The following is a description of a gene set: from publication Busconi L, Bauer JW, Tumang JR, Laws A, Perkins-Mesires K, Tabor AS, Lau C, Corley RB, Rothstein TL, Lund FE, Behrens TW, Marshak-Rothstein A (PMID 18025183) We have previously shown that rheumatoid factors (RF) produced by Fas-deficient autoimmune-prone mice typically bind autologous IgG2a with remarkably low affinity. Nevertheless, B cells representative of this RF population proliferate vigorously in response IgG2a/chromatin immune complexes through a mechanism dependent on the sequential engagement of the BCR and Toll-like receptor 9 (TLR9). To more precisely address the role of both receptors in this response, we analyzed the signaling pathways activated in AM14 B cells stimulated with these complexes. We found that the BCR not only serves to direct the chromatin complex to an internal compartment where it can engage TLR9 but also transmits a suboptimal signal that in combination with the signals emanating from TLR9 leads to NF-kappa-B activation and proliferation. Importantly, engagement of both receptors leads to the upregulation of a group of gene products, not induced by the BCR or TLR9 alone, that include IL-2. These data indicate that autoreactive B cells, stimulated by a combination of BCR and TLR9 ligands, acquire functional properties that may contribute to the activation of additional cells involved in the autoimmune disease process. Human Gene Set: GSE6674_ANTI_IGM_VS_ANTI_IGM_AND_CPG_STIM_BCELL_DN studied in species Homo sapiens Genes down-regulated in B lymphocytes: anti IgM versus anti IgM and CpG oligodeoxynucleotide 1826., and this is the list of marker genes: NDFIP2, EIF3B, KIAA1191, ERGIC1, GOLGA7, HSPA4, CNDP2, DCTD, MRPS10, NOL9, SPRED1, SLC52A2, AFG2B, ASNS, NOL10, MFSD2A, RCN1, EXOSC7, ZNF608, UBQLN1, HEMK1 (NCBI Gene Id 51409), CISH (cytokine inducible SH2 containing protein), SESN2, AEN, MTHFD1 (NCBI Gene Id 4522), PPAN (peter pan homolog), LTA (NCBI Gene Id 4049), FBXO30, TMCO3, PPHLN1 (NCBI Gene Id 51535), ATAD3A (NCBI Gene Id 55210), NOC2L, SLC7A5, PRMT1, PIM1, SEPTIN9, KCNK5, ZCRB1, SND1, CCT3, C7orf50, TGIF2, REXO2, PUM3, NDUFAB1, ELP1, ACLY, NOC4L, SLC4A7, KANSL2, ADSL, EBNA1BP2 (EBNA1 binding protein 2), LRP8, AQP9, PANK3, TIMM8A, HSPA9, TAFA3, SLC2A1, CHCHD4, UTP15, TGFB1, BCL2L1, G3BP1, HOMER1 (homer scaffold protein 1), UCK2, DIS3, MAT2A, LARP4, DDX54, PGLYRP2, KAT2A, SOCS1, SMYD5, PRNP, NAP1L4, YAF2 (NCBI Gene Id 10138), BTG3, TBRG4, C1QBP, GNL2, ARID5A, ATIC, PPP1R3B, CHAC1, CCDC86, HOOK1, SHMT1, PC, BDH1, SNRPA, MARS1, TNFRSF9, HBEGF, ELAVL1, FBL, NOLC1, PIM3, MYC, IFRD2, FAM118B, PHB1, NHP2, SMYD2 (SET and MYND domain containing 2), EIF2B3 (NCBI Gene Id 8891), ZMYND19, CYB5A (NCBI Gene Id 1528), XPOT, IFNG, USP27X, CLPTM1L, IDH3A, RRP1B, GPD2, NSUN5, RRAGD (Ras related GTP binding D), MAK16, SYPL1 (NCBI Gene Id 6856), BMS1, EIF2S1, TRIB3, GEMIN4, TEX2, CTPS1 (NCBI Gene Id 1503), NOP2, POLD2, NOL11, GARS1, FKBP1A, HCCS, WDR74, TMEM158, NLE1, WDR36, CCND3, ZNF507, PRPF31, EXOSC1, SLC39A6 (solute carrier family 39 member 6), ITIH5, TXNRD1, DPH5, LARP1, DCUN1D2, RASA2, AHCYL2, AFG2A, HK2 (hexokinase 2), AGPAT3, NIP7, EXOSC2, PSMG1, BYSL, CDK6, NARS1, BOP1 (BOP1 ribosomal biogenesis factor), FNIP2, EIF3G, EIF4A3, DNAJA3, EEF1E1, ARL14EP, HSD17B7, PRPS2, FARSB, SRM, ABHD17B, TUT1, CDCA7L, UTP18, YARS1, SPRY1, PDIA6, DIMT1, SENP3, RWDD3, CDKN1A, TARS1, DEGS1, TNF, AARS1, LARS1, MRE11, GADD45G, SNHG17, EXOC5, LRP12, UTP25, MTHFD2, YDJC, GPT2, CAND1, TMEM185A, GPS1, GCSH, C3orf18 (chromosome 3 open reading frame 18), STC2, SOD2, MYBBP1A